The following is a description of a gene set: Mouse Gene Set: GOBP_SUCCINYL_COA_METABOLIC_PROCESS The chemical reactions and pathways involving succinyl-CoA, a compound composed of the monovalent acyl group 3-carboxypropanoyl, derived from succinic acid by loss of one OH group, linked to coenzyme A. studied in species Mus musculus, and this is the list of marker genes: Sucla2, Mmut, Suclg2, Mmaa, Acot4, Dlst, Nudt8, Nudt7 (nudix hydrolase 7), Nudt19, Oxct2a, Ogdh, Suclg1